Given this list of marker genes VDAC3 (NCBI Gene Id 7419), PTEN, VDAC1, PNOC, TMOD2, DLGAP2, OPRL1, DRD2, KIF1B, here is a description of the gene set: species: Homo sapiens Human Gene Set: GOBP_NEURON_NEURON_SYNAPTIC_TRANSMISSION The process of synaptic transmission from a neuron to another neuron across a synapse.